Given this list of marker genes SLC3A2, CRH, SLC25A15, SLC18A1, SLC44A3, SLC36A1, ADORA3, SLC1A5, RGS2, RHAG, CLTRN, SLC18A3, SLC7A10, ACTB, STX1A, SLC22A2, SLC6A2, SLC25A17, PDZK1, SLC22A3, VIP, AQP8, SLC15A4, GABBR1, SLC29A4, LLGL2, SLC6A14, SLC11A1, P2RY1, SLC38A2, NFE2L1, SLC43A2, FLVCR2, SLC7A5, SLC19A3, ACE2, SLC38A1, FLVCR1 (FLVCR choline and heme transporter 1), SLC1A2, SLC16A10, SLC18B1, SLC25A38, SLC6A15, SLC16A9, SLC7A1, SLC7A7 (solute carrier family 7 member 7), SLC25A29, SLC19A2, SLC36A2, TACR2, SFXN1, SLC22A1, SLC6A17, PSEN1, SLC44A2, SLC38A4, ABCB1, SLC36A4, SLC6A20, SLC32A1, SNCA, SLC66A1LP, SLC6A3, SLC36A3, ATP13A3, GHSR, FFAR3, SLC25A2, SLC35F3, RGS4, SEC14L1, CHRNA3, COMT, ADRA2A, SLC38A3 (NCBI Gene Id 10991), SLC66A1, TSPO2, SLC5A7, SLC7A6, SLC29A3 (NCBI Gene Id 8072), SLC6A7, SLC6A6, SLC25A19, SLC7A2, SLC38A9 (NCBI Gene Id 153129), SLC1A4, KCNB1, SFXN2, SLC6A12, SLC43A1, SLC22A5, SLC7A8, SLC22A4, SLC22A16 (solute carrier family 22 member 16), CARTPT, SERINC3, SLC7A3, SLC44A4, ADRA2B, SLC17A8 (solute carrier family 17 member 8), SLC47A1, MFSD12, SLC25A42, SERINC5, SLCO1A2, CLN3, SFXN3, SLC1A1, ADRA2C, SLC44A5, ADORA2A, SLC38A5, SLC47A2, SLC25A26, SLC22A18, SLC6A5, SLC6A9, SLC25A20, SLC44A1, OXT, RALBP1, here is a description of the gene set: The directed movement of organic cations into, out of or within a cell, or between cells, by means of some agent such as a transporter or pore. Organic cations are atoms or small molecules with a positive charge which contain carbon in covalent linkage. species: Homo sapiens Human Gene Set: GOBP_ORGANIC_CATION_TRANSPORT